The following is a description of a gene set: Any process that results in a change in state or activity of a cell or an organism (in terms of movement, secretion, enzyme production, gene expression, etc.) as a result of an alcohol stimulus. Human Gene Set: GOBP_RESPONSE_TO_ALCOHOL species: Homo sapiens, and this is the list of marker genes: SLC5A5, CSF3, F7, CRH, GNB1, BLM, SREBF1, MAP4K1, XRN1, FOS, ADH7, CASP8, IL2, TSPO, HDAC6, DAG1, PTCH1 (patched 1), SH3RF1, GNG2, MT-ND4, ZNF212, PENK, PTGER2, PMVK, UCP1, PRKCE, MDM2, CD4, RPL10A, SLC12A3, JUP, SLIT2, MIR342, CCR7, FOXP3, PRKAA1, FGF2, ABAT, GPLD1, CCL3, SMAD2, SETD7, GATA3, ATP5F1A, DNMT3A, BCL2L1, PSMD14, SCNN1B, ITPR2, AHR, GRAMD1C, ADRA2A, GRIA1, GNAI1, BIRC2, RELA (NCBI Gene Id 5970), LRP6, TGFBR3, CAD, GLRA2, FKRP, NR0B2 (NCBI Gene Id 8431), DEFB104B, ADCY7, SLIT3, ADIPOQ, CCL21 (C-C motif chemokine ligand 21), SGK1, FECH (NCBI Gene Id 2235), LIPA, EFNA5, DRD4, TNF, NPPC, CDK1, LRP8, GPR155, CDK4, RPS6, GRAMD1B, TNC, OXCT1, COMT, USP46, CYP8B1, GNAS, FOSB, PPP1R9B, FYN, PRKAA2, TNFRSF11A, TACR1, SCNN1D, OPRM1, GRIN1, GHR, AKR1C3, IFITM5, GNAQ, SLC10A1, ADCY8, IL13, AKAP8 (NCBI Gene Id 10270), INHBB, H6PD, RBP4, CAT, FGFR2, CYBB, ALAD (NCBI Gene Id 210), ELK1, TP53INP1, MIR96, NR3C1 (NCBI Gene Id 389335), FDX1, ADCY5, STAT3, SCN11A, PRKD1, ADCY2, PRKN, ABCA2, UCN3, ADCY3, RECQL5 (NCBI Gene Id 9400), TBXA2R, SOD1, HMGCS2 (3-hydroxy-3-methylglutaryl-CoA synthase 2), BORCS7, P2RY4, SCNN1A, TNFSF4, ALAS1, OSBPL7, GRIN2B, EEF2, DRD3, FOXO3, DRD2 (dopamine receptor D2), MIR182 (microRNA 182), RAD51, CREB1, CES1, SCNN1G (sodium channel epithelial 1 subunit gamma), GNRH1, OPRK1, HNRNPD (NCBI Gene Id 548), PTGFR, CRHBP, NTRK3, GSTP1, DBH, CLDN3, AVP, ABCA1, SLC6A3, CRHR1, STK39, FGF19, EPS8, GOLPH3, S100A8 (NCBI Gene Id 6279), GOT2, BAK1, TGFB1, DYNAP (dynactin associated protein), NPAS4, CALM3, CTNNA1, GKN2, CYP7A1, CCR5, CDH1, G6PD, CD68, OPRD1, PPARA, DEFB104A, HCRT, PTGER4, CARD9, ADCY6, RGS4, IGFBP7 (insulin like growth factor binding protein 7), AKT1, CDO1, BRCA1, VCAM1, CPT1A, AVPR1A, CCL7, INHBA, CLDN5, KLF9, CYBA, GABBR1, OXT, SMO, GRAMD1A, ACACA, PTGDR2, FKBP5 (NCBI Gene Id 2289), CLDN1, HDAC2, EEF1B2, GRIN2A, SDF4, TGFBR2, MSTN, PTPRC, PTH, NFE2L1, P2RY6, PTGER1, BTG2, RGS2, CCL19, CDA, ANKRD13C, CFTR, ABCB1 (NCBI Gene Id 5243), LARP1, DMAP1, ADCYAP1R1, RARA, MT-CYB, PTGDR, CCND1, CSN1S1, ADAM15, CLDN18, FBP1, HPGD, SFRP1, MLC1, GLB1, NEFL, CD27, SPHK2, PRKCA, SPI1, PIM3, GLRA1, AANAT, SPIDR, SLC2A4, MYD88, MAPDA (N6-Methyl-AMP deaminase), HCN2, ACTC1 (actin alpha cardiac muscle 1), KLF2 (KLF transcription factor 2), AIFM1, PARP1, SLC23A2, CA3, LANCL2, ADCY1, CTNNB1, SOD2, KCNC2, TGFBR1, BGLAP, MIR185, AKR1C2, TBXAS1, CHRNB2, GRIN3A, KLF4, LEP, TH, POLB, CBL